The following is a description of a gene set: A process that is carried out at the cellular level which results in the assembly, arrangement of constituent parts, or disassembly of an autophagosome. studied in species Mus musculus Mouse Gene Set: GOBP_AUTOPHAGOSOME_ORGANIZATION, and this is the list of marker genes: Wipi2, Nupr1, Gm12185, Rab3gap2, Tgtp2, Moap1, Ralb, Rab19, Fez1, C9orf72 (C9orf72, member of C9orf72-SMCR8 complex), Cln3, Mtm1, Ift88, Atg3, Irgm2, Pikfyve, Nsfl1c, Pip4k2b, Atg14, 9930111J21Rik1, Ulk1, Mfn2, Atg4a-ps, F830016B08Rik, Ulk2, Stbd1, Iigp1c, Gabarap, Atg2a, Igtp, Atg10 (autophagy related 10), Snx30, Atg9b, Becn2, Sting1, Atg4c, Ifi47, Rab1a, Pip4k2c, Psen1, Gabarapl2, Rab43, Atg4a, Gabarapl1, Wipi1, Stx17, Elapor1, Stx12, Lrsam1, Pip4k2a, Becn1, Dnajc16, Atg16l2, Phf23, Zfyve26, Lrba, Rufy4, Arfip2, Ehmt2, Chek2, Mtor, Atg101, Epm2a (NCBI Gene Id 380675), Tmem39a, Sec22b, Ap5z1, Ubqln1, Rab33b, Snx18, Lrrk2, Rab7, Tbc1d14, Rab3gap1, Pacs2, Trp53inp1, Fez2, Rab23, Ubqln2, Gm12250, Atg13, Ift20, Ctsd, Atg4b, Tmem41b, Traf6, Ambra1, Vmp1, Map1lc3b, Irgq, Emc6, Tcirg1, Gba1, Smurf1, Trim32, Wdr45b, Gm4841, Rab33a, Atg4d, Gm5431, Rnf5, Snx7, Rab1b, Smcr8, Atg5, Elavl1, Atg2b, Pik3c2b, Synpo2, Map1lc3a, Ap4m1, Tom1, Atg7, Ulk3, Mtmr3, Snx4, Trp53inp2, Atp2a2 (ATPase, Ca++ transporting, cardiac muscle, slow twitch 2), Atg9a, Spg11, Ubxn2b, Irgm1, Scfd1, Atg12, Wdr45 (NCBI Gene Id 97597), Pink1, Rnf186, Rb1cc1, Sh3glb1, Iigp1, Tbc1d12, Efnb1, Ephb2, Pik3c3, Atp13a2, Tgtp1, Atg16l1, Ubxn2a, Pik3c2a